Given this list of marker genes Aldob, Trp53, Mtor, Mlst8, Hsd11b1, Tigar, Rptor, here is a description of the gene set: Any process that modulates the frequency, rate or extent of the pentose-phosphate shunt, the process in which glucose is oxidized, coupled to NADPH synthesis. Mouse Gene Set: GOBP_REGULATION_OF_PENTOSE_PHOSPHATE_SHUNT species: Mus musculus